Given this list of marker genes CCL13, CCL24, CCL19, CCL21, CCL4L2, CCL7, CCL2, CCL5, CCL4, CCL11, DAPK2, CCL26, CCL25, SCG2, CCL22, CCL16, CCL3, CX3CL1, LGALS3, CCL8, CCL1, here is a description of the gene set: The movement of an eosinophil in response to an external stimulus. studied in species Homo sapiens Human Gene Set: GOBP_EOSINOPHIL_CHEMOTAXIS